Given this list of marker genes PAX6, SHH, SMAD4, GDF3, NODAL, SSBP3, NTF4, here is a description of the gene set: studied in species Homo sapiens The process in which the limits of an anatomical structure are generated. An anatomical structure is any biological entity that occupies space and is distinguished from its surroundings. Anatomical structures can be macroscopic such as a carpel, or microscopic such as an acrosome. Human Gene Set: GOBP_FORMATION_OF_ANATOMICAL_BOUNDARY